Given this list of marker genes Serpinf1, Aurka, Cck, Ndel1, Adcy1, Prkcz, Map2, Htr1a, Tpx2, Sptbn4, here is a description of the gene set: Portion of the neuronal cell soma from which the axon originates. Mouse Gene Set: GOCC_AXON_HILLOCK species: Mus musculus